Given this list of marker genes STOML2, MRPL16, WARS2, TIAM1, NOL7, MPC2, CDC26, MRPL22, CBLN4, RUVBL2, SPRY1, SYNE2, GNPTAB, CD276, DTD1, AKNA, SKIDA1 (SKI/DACH domain containing 1), HTATSF1 (HIV-1 Tat specific factor 1), PRKRIP1, CFAP20, AURKAIP1, PUM3, UTP15, MTX1, POU4F1, SPINT1, KCTD5, CR1L, GARRE1, MAP6 (microtubule associated protein 6), CASP1, GLRX5, C1QBP, GRK5, BCL2L13, CALML4, MS4A6A, POLD2, NUP205, NDUFAB1, CCN4, LRRC45, RPF2, TIMM22, DUSP2, BCAS2, FBXO31, MRPL11, TAF6, SMIM8, RCN2, DEAF1, RTN4RL1, SHCBP1L, ABT1, ARID5B, TLR9, WDR55, C3orf52, ICOS, SNRNP200, NLN, IL20RA, SSR2, LIN7A, NONO, L2HGDH (NCBI Gene Id 79944), SMN1, HSPE1, EMB, TUSC3 (tumor suppressor candidate 3), FAM193A, ZC3HC1, UQCC2, CD200, POLR2F, ARHGEF3, ADI1 (NCBI Gene Id 55256), COBLL1, C1orf52, PABPC4L, CES3, JAZF1, SLAMF1, PTCD2, TRPV1 (transient receptor potential cation channel subfamily V member 1), RPF1, RSAD1, DALRD3, INPPL1, PDE3B, SUMO3, SSMEM1, MLXIP, INSYN2B, XKR5, SLC26A10P, DCLK1, MCM6, ARFRP1, ATP5MF, AFG2B, FASTKD1, YBX3, MRPS30, ECD, TNRC18, FCF1, GPR89B, CAGE1, GABRB1, ETS2, CCT5, FH, E2F6, TMCC2, VMP1, ZFP36L1, CLPB, POGLUT3, PCDH10, MMP8, SNHG3 (NCBI Gene Id 8420), EIF2AK1, NR6A1, ITGB5, KYAT3, MICOS10, SAFB2, TREX1, ELMO1, ARF1 (NCBI Gene Id 375), DDX28, DNAJC24, TTC4, PPHLN1, B3GLCT, PKNOX1, IWS1, SUGP1, CDH2, CALR, CCDC122, ART3, SGF29, FILIP1L, ACSM2A, APOBEC1, SDAD1, BANF1, SSPN, PRSS41, ECE1 (endothelin converting enzyme 1), CDC20 (NCBI Gene Id 991), CTNNBL1, CST7, TIMM8B, TMEM267 (transmembrane protein 267), ZNF469, C8orf34, SAMM50, MSH2 (mutS homolog 2), PHETA2, TEX47, MIOS, PRKCZ (NCBI Gene Id 5590), DIMT1, RMDN2, SNRPA1, CDH7, DGKK, BRF2, ITGA3, CBX2, NRROS, PTGES2, ANAPC15, WDR26 (NCBI Gene Id 80232), NQO1, NSFL1C, COQ2, IPO11, WBP11, GGA2, MMACHC, CASQ1, CAMK2D, TMEM229B, CRACD, DNAJC15 (NCBI Gene Id 29103), COQ7, PDXK, LAS1L, NUP37, ERCC3, CNBP, RWDD4, ST3GAL5, KLHDC9, FNTA, here is a description of the gene set: species: Homo sapiens In order to better understand the factors that regulate B cell differentiation upon exposure to antigen, we compares global gene expression profiles from naive B cells with antigen-specific plasma, germinal center, and memory B cells after immunization with the T-dependent antigen, NP-CGG. The memory B cell-enriched transcripts were then compared with memory T cell-enriched and hematopoietic stem cell-enriched transcripts in order to generate a transcriptional profile of self-renewal within the hematopoietic system. from publication Luckey CJ, Bhattacharya D, Goldrath AW, Weissman IL, Benoist C, Mathis D (PMID 16492737) Human Gene Set: GSE4142_PLASMA_CELL_VS_GC_BCELL_DN Genes down-regulated in plasma cells versus germinal center B lymphocytes.